Given this list of marker genes GON7, TP53RK, TPRKB, LAGE3, OSGEP, here is a description of the gene set: A protein complex involved in t6A tRNA modification. For example, in Saccharomyces cerevisiae the complex contains Bud32p, Kae1p, Gon7p, Cgi121p, and Pcc1p. Human Gene Set: GOCC_EKC_KEOPS_COMPLEX studied in species Homo sapiens